The following is a description of a gene set: Transposition of the great arteries species: Homo sapiens Human Gene Set: HP_TRANSPOSITION_OF_THE_GREAT_ARTERIES A complex congenital heart defect in which the aorta arises from the morphologic right ventricle and the pulmonary artery arises from the morphologic left ventricle., and this is the list of marker genes: FOXJ1, SPAG1, SMAD2, SPEF2, GJA5, DNAH11, STK36, GPC4, NODAL, ZMYND10, RSPH4A, DNAAF3, CFAP300, DRC1, DAW1, ATP2B1, BMP2, TBX1, DNAAF5, GNB2 (G protein subunit beta 2), ZIC3, FKTN, FANCB, DNAI1, CCNO, PLXND1, ZNF462, MCIDAS, NKX2-5, DNAAF4, OFD1, CCDC40, RPGR (retinitis pigmentosa GTPase regulator), DNAAF1, MMP21, DNAAF11, CCDC39, WT1, DNAH5, CFAP74, RSPH9, ODAD3, CFAP53, SMG9, GATA6, MED13L, DNAJB13, ACVR2B, CIROP, ODAD1, PIGL (NCBI Gene Id 9487), DNAH1, MEGF8, RSPH3, RAB23, TTC12, RSPH1, PHGDH, NEK10, DNAI2, GJA8 (NCBI Gene Id 2703, gap junction protein alpha 8), NKX2-6, DNAH9, GATA4, LRRC56, HYDIN, ODAD4, DNAAF2 (dynein axonemal assembly factor 2), ZMPSTE24, CFAP221, ODAD2 (outer dynein arm docking complex subunit 2), GPC3, DNAAF6 (dynein axonemal assembly factor 6), GAS2L2, NME5, LMNA, NME8, CFAP298, QRICH1, DNAL1, GDF1, CFC1